Given this list of marker genes Abca7, Atp11a, Atp10d, Atp8b5, Atp11b, Abcg1, Tmem30a, Atp8b2, Atp10b, Atp9a, Abca2 (ATP-binding cassette, sub-family A member 2), Abcb1a, Atp9b, Atp8a2, Atp8a1, Abca12, Atp8b3, Abca1, Atp11c, Atp8b1, Atp10a, Abca4, Abcb1b, Atp8b4 (NCBI Gene Id 54669), Tmem30b, Mfsd2a, Abcb4, Abca3, here is a description of the gene set: Mouse Gene Set: GOMF_ATPASE_COUPLED_INTRAMEMBRANE_LIPID_TRANSPORTER_ACTIVITY Catalysis of the movement of lipids from one membrane leaflet to the other, driven by ATP hydrolysis. This includes flippases and floppases. species: Mus musculus